The following is a description of a gene set: Human Gene Set: GSE8921_UNSTIM_VS_TLR1_2_STIM_MONOCYTE_12H_UP Genes up-regulated in monocytes (12h): untreated versus M. tuberculosis 19 kDa lipopeptide. from publication Liu PT, Stenger S, Li H, Wenzel L, Tan BH, Krutzik SR, Ochoa MT, Schauber J, Wu K, Meinken C, Kamen DL, Wagner M, Bals R, Steinmeyer A, Zügel U, Gallo RL, Eisenberg D, Hewison M, Hollis BW, Adams JS, Bloom BR, Modlin RL (PMID 16497887) studied in species Homo sapiens In innate immune responses, activation of Toll-like receptors (TLRs) triggers direct antimicrobial activity against intracellular bacteria, which in murine, but not human, monocytes and macrophages is mediated principally by nitric oxide. We report here that TLR activation of human macrophages up-regulated expression of the vitamin D receptor and the vitamin D-1-hydroxylase genes, leading to induction of the antimicrobial peptide cathelicidin and killing of intracellular Mycobacterium tuberculosis. We also observed that sera from African-American individuals, known to have increased susceptibility to tuberculosis, had low 25-hydroxyvitamin D and were inefficient in supporting cathelicidin messenger RNA induction. These data support a link between TLRs and vitamin D-mediated innate immunity and suggest that differences in ability of human populations to produce vitamin D may contribute to susceptibility to microbial infection., and this is the list of marker genes: NATD1, OSBPL2, ABHD1, PALS1, MARCKS, SSBP2, PIM1, CCRL2, PLPPR4, STEAP4, UBE2E3, CTC1, PLEKHH1, EPB42, PECR, LEPROT, SGSH, C15orf61, CACNG2, COL20A1 (collagen type XX alpha 1 chain), DNAH8, TPD52L2, MBOAT7, LAGE3, RPS9, ALDH16A1, RNF6, COL14A1, TNFRSF14, CCNDBP1, ZDHHC24, NDFIP2, SLC9A9, ATP6V0E1, SNCA, ZMAT4, FAM234B, ARRDC3, CCDC186, SCEL, MAGED1, AATF, PDXDC1, MEGF9, IFNAR2, HDAC4, SCAMP5, CTNNBIP1, P2RY2, DYNLT1, PIK3C2A, CEBPD, IGSF8, F2R, RBM7, ZNF43, DARS2, PEX11A, PAK1, NCF4, SNAPC3, SNX13, WDR59, TFRC, SLC28A2, ADCY3, NNT, GCH1, TIRAP, TLCD2, TTL, BMPR1A, RNF32, SPON1, RCN3, TMCO6, MMP12, TIGD5, UBR3, LSM11, MON2, AS3MT, TIPARP, PPCDC, QPCTL, PLA2G7 (phospholipase A2 group VII), HEBP1, DEDD2, FOXJ1, GLUL, BCL2L15, EVA1A, NIPA1, GLRX, CLASP2, THBS1, DNMBP, TGDS, UGT8, GSS, TIFA, CCL24, ABCA3, ATP8A1, INPP4B, ITPRIPL1, NUDCD3, SLC7A7, ADA, HYI, NUDT18, PLOD3, SKIC3, LHFPL6, FBXL2, PI4KB, PLAGL1, SLC25A33, GSPT2, CIMIP6, GSTA3, DYNLT2B, DACH1, VSTM4, FRG1, DUSP6, CDKL2, MDH2, CLEC16A, NGRN, ATP10D, MAF, FUOM, LZTFL1, DENND2D, TEX35, CABS1, RAB34, UTP4, PHYH, SCOC, QSOX1, FCGRT, TMOD4, FKBP9, KCTD6, NAPEPLD, TENM4, INPPL1, DOCK4, ITGB1BP1, C5AR1, ACBD4 (acyl-CoA binding domain containing 4), SLC3A2, NIPSNAP1, ATP6V0E2, LRP1, SLC4A7 (NCBI Gene Id 9497), IL1R1 (NCBI Gene Id 3554), CERS5, TRAPPC9, GAS6, STK35, ADIPOR2, SCYL2, ZFP36L2, TLR6, BMP2K (BMP2 inducible kinase), RNF167, OXNAD1, LONRF1, PI4K2A, SORT1, GPER1, FAM135A, B3GLCT, MAN2B1, SAT1, SVIP, GFRA4 (NCBI Gene Id 64096), CMC2, TCEAL8, GLO1, TRIM68, TENT4A, AP1M1, AAR2, RCAN3 (NCBI Gene Id 11123), HSH2D, ITGA9, PIK3CG, ACSL3, FBP1, HDDC3, ABCC3, TMEM248, PLS3, USP33, C3orf70, FUCA2